The following is a description of a gene set: Any process that modulates the frequency, rate or extent of blood vessel endothelial cell proliferation involved in sprouting angiogenesis. species: Mus musculus Mouse Gene Set: GOBP_REGULATION_OF_BLOOD_VESSEL_ENDOTHELIAL_CELL_PROLIFERATION_INVOLVED_IN_SPROUTING_ANGIOGENESIS, and this is the list of marker genes: Pdcd10, Jcad, Hmox1, Fgfbp1, Agtr1a, Mmrn2, Ngfr, Dll4, Vegfa, Ppp1r16b, Il12a, Apela, Agtr1b, Aplnr, Thbs1, Gata2, Il12b